Given this list of marker genes SMAD2, GUCY1A1, TENT4B, TNFRSF11A, CNOT4, KLF15, CDYL2, ZNF799, LIX1L, ZNF711, STMN3, UGCG, PEA15, NIPAL2, ST6GAL2, ATL2, RAD51B, MARK1, CPEB3, BACH2, AKR7A2, PPP3CB, HECA, PROX1, YWHAQ, MCOLN2, IP6K1, STIL, CPNE8, TMEM201, CACNB2, ZNF443, DAG1, G3BP1, RNF103-CHMP3, CREBRF, STK38L (NCBI Gene Id 23012), KIF5C, RSBN1, TNFSF8, MDM1, B3GNT2, GPRASP3, HPS3, INTS6L (integrator complex subunit 6 like), MTFR1L, ZFHX2, SCUBE3, LHFPL2, CHMP3, ZNF44, ST6GALNAC1, PDS5B, ENTPD1, CBX1, PAFAH1B1, here is a description of the gene set: species: Homo sapiens from publication Chen Y, Wang X (PMID 31504780) Human Gene Set: MIR4305 Genes predicted to be targets of miRBase v22 microRNA hsa-miR-4305 in miRDB v6.0 with MirTarget v4 prediction scores > 80 (high confidence targets).